The following is a description of a gene set: from publication El Kasmi KC, Holst J, Coffre M, Mielke L, de Pauw A, Lhocine N, Smith AM, Rutschman R, Kaushal D, Shen Y, Suda T, Donnelly RP, Myers MG Jr, Alexander W, Vignali DA, Watowich SS, Ernst M, Hilton DJ, Murray PJ (PMID 17114459) studied in species Homo sapiens IL-10 or IL-6 stimulation of control 129xC57BL/6 murine bone marrow derived macrophages in the presence of LPS. We used microarrays to detail the global programme of gene expression changes in response to IL-6 or IL-10 stimulation in the presence of lipopolysaccharide. BMDMs were isolated from control, IL-6-/-, and IL-10-/- mice on a 129XBL/6 mixed background mice and differentiated in the presence of CSF-1 for 6-7 days. Cells were scraped and plated in 6 well plates at 2x10e6/well. Cells were washed with complete DMEM and rested for 1-2 hr before stimulation with combinations of IL-10 (10 ng/ml), IL-6 (2 ng/ml) or LPS (100 ng/ml) for 45 min or 180 mins. Complete biological replicates were performed. Genes up-regulated in bone marrow-derived macrophages with IL10 and 180 min stimulation of: LPS versus IL10 and LPS. Human Gene Set: GSE5589_LPS_VS_LPS_AND_IL10_STIM_IL10_KO_MACROPHAGE_180MIN_UP, and this is the list of marker genes: SLC38A3, TPR (NCBI Gene Id 7175), ARID1B, ASB4, HBA2, LDHA, TPBG, PTPRN2, RAB19 (RAB19, member RAS oncogene family), RBM6, BOK, ATF7IP2, LIMA1, MGST2, PON2, APRT (NCBI Gene Id 353), BLTP3B, MITF, C8orf34, PNOC, COX20, MOK, HSPB2, RPUSD4, SORT1, S100A5, ABCG1, NAALADL1, ADIPOQ, CEP15, STX5, CD38, STAR, APCDD1, CHCHD2, NME5, LRGUK, PRELID3A, HS3ST3B1, PTPRK, MAP9, ZFR2, ANO3, ANGPTL4, SLC16A10, F8, GALNT15, ZNF616, PRRC2C, ARHGAP39, FSCN1, KIF9 (NCBI Gene Id 64147), KCNK7, SP4, CNKSR2, BCAP31 (NCBI Gene Id 10134), MGLL, B3GNT7, WDR55, ZNF251, DYNC1I1, BEX1, SH3RF2, CREG2, MFAP1, NDUFS6, SOAT1, STARD10, SEC14L5, PKN1, DENND4B, SLIT3, GADD45A, GHRL, HAL, TUSC2, CAMKV, MBD5, EPS8L3, NCEH1, SOX9, LYPD1, GPR137B, OPN4 (NCBI Gene Id 94233), B3GALT5, SLC51A, CCDC106, TSKS, ZDHHC18, PKDCC, FAH, ZFP30, IGF1R, SMC6, CA1, FEN1, HPGDS, TBC1D8, FABP4, NLRP9, TTC9B, PLIN2, KBTBD13, IGSF23 (NCBI Gene Id 651819), DDX17, SPECC1, SLC8A1, SLC37A2, SLCO2B1, CSNK2A1, PCP4, GPR161, PRSS53, LDAF1, TP73, AP1M2 (adaptor related protein complex 1 subunit mu 2), WNT4, ENPP1, ARG2, CELA1, POM121L12, ERMP1, UROS, CORO6, PPP2R5A, CD200, SLC5A1, ZNF592, FTL, CRHBP, DEFB106B, IL17RA, SCML4, VSIG2, SPNS3, AKR1B1, SNIP1, AEBP2, CDH22, CPT1A, FERD3L, ZFP69 (NCBI Gene Id 654213), MPP7, GRK3, IP6K3, NEDD4, ELFN2, CLASP2, HCRT, ST8SIA4, CEP135, PDE1A, CES3, WHRN, DCBLD1, NCOR1, DGKQ, KCNE1, PROZ, NGB, TNFRSF18, SORL1, ENO4, BBOX1, TRIM29, MGST1, GLUL, EFCAB6, TGFBR2, NDN, CDHR4 (cadherin related family member 4), CMBL, RBM4B, GDPD1, KMT5A, SCG3, PPIP5K1, GAB3, APOBEC2, HCN2, SETD2, SGCD, VAX1, ABR, SH2D1B, ICOSLG, KCNQ1OT1, SOX13, SRRM2, RRP36, TASL, EPPIN, ETFB, SHPK (sedoheptulokinase), NLRP12, ART5, NPHP4, CD8A, ETV6, IL22RA2